Given this list of marker genes DDX55, DUSP15, PSMB7, JKAMP, ECHDC1, TAF1A, RPRD1A, PTPRK, EMB, SNX13, SDAD1, ZBTB44, WDR5, AP1G2, CEP95, GGA2, CAPN7, ABI2, AEN, C1orf159, NBEAL1, DUSP12, EEF1G, GART, STAG3, RAB6A, RTN4, ZNF679, ARFIP1, RNF103, NIPBL, IPCEF1, MTURN, DIP2A, KDM1B (lysine demethylase 1B), ACADM, DAGLB, RECK, SWT1 (SWT1 RNA endoribonuclease homolog), PSMG2, PDE2A, SLC16A8, SESN1, ATP6V1D, CBX7, METAP1D, VPS13A, SORL1, YBX1, GRK6, LRRC75B, PTBP3, CDKL2, TAGAP, GARIN3, HNRNPF, LRRC40, RNF145, P2RX4, SETD7, RGS20, AMY2A, PTS, MAN2A1, STOML1, CARNMT1, TTC28, HMGB1, UBASH3B, GLCCI1, PTPN12, SMPD5, KLRK1, NTAQ1, RAB2A, ZDHHC23, THEMIS, SLC35D2 (solute carrier family 35 member D2), PANK1, ABCC5, EFEMP1, SLC7A3, OAZ2, PTCH1, UBE2Q2, TTYH3, MADD, BIVM, ARHGEF3, RPS6KA5, COQ3, MAP1LC3B, FGF2, C19orf38, CSNK2A1, SMC4, MALT1, ASB1, XPC, ZBTB20, ATP8B2, ARHGAP18, ARFRP1, PON2, GUCD1, SPRY1, RXRA, APPL2, IP6K1, VSIR, C12orf75, TMEM267, STK26, PXYLP1, GLE1, RBM27, YWHAZ (NCBI Gene Id 83242), LDLRAP1 (NCBI Gene Id 81862), RB1CC1, CYP2S1, PURG, TUBA1A, CRYBG3, ANKMY2, GTF2I, GRAMD4, PFAS, DHRS11, SRGAP2, ARL4A (ADP ribosylation factor like GTPase 4A), UAP1, ACSBG1, RUNX2, ACOT9, NAE1, RNF141, NEAT1, SPOP, DSN1, ZNF318, SLC35E3, EVI2B, TIMM21, ME3 (malic enzyme 3), RORA, HNRNPA0 (heterogeneous nuclear ribonucleoprotein A0), RDH10, FNDC1, DTX4, KLHL6, FASTKD1, RAMP1, ANKH, MICALL1, DHFR, MYH9, NCAPD3, UBE2D2, PCMTD1, PLA2G4F, CDC25B, HSD11B2, METTL2B, UBQLN1, ZNF251, CXXC5, UBE2H, B3GALNT2, SORBS1, FCGR2A, CDC42SE2, OTUD1, ATRN, MORN2, ARHGAP31, MCOLN3, RHEBL1, SRSF5 (NCBI Gene Id 6430), UTRN, KMT2E, CISD3, TRAK1 (NCBI Gene Id 22906, trafficking kinesin protein 1), EGFL6, SLC25A26, ATXN3, CDC14B, DGKB, FAM117B, TPCN1, CEP78, FAM177A1, PIEZO1, ISCA2, TMX4, RNF144A, SF1, JADE2 (jade family PHD finger 2), ADH5, TMBIM1, RNF39, here is a description of the gene set: from publication Ventre E, Brinza L, Schicklin S, Mafille J, Coupet CA, Marçais A, Djebali S, Jubin V, Walzer T, Marvel J (PMID 22942430) Effects of IL-4 on CD8 T cells functions are largely unknown. IL-4 induces survival and proliferation of CD8 T cells, but several studies suggest that IL-4 could also affect several functions of CD8 T cells such as cytotoxicity. Our team has shown that IL-4 repress the expression of Ccl5 in vitro. To define more precisely the impact of IL-4 on CD8 T cells, we performed a whole genome expression microarray analysis of naive and memory CD8 T cells cultured in presence or absence of IL-4. This approach allowed us to define the IL4-gene-expression signature on CD8 T cells. Human Gene Set: GSE32423_IL7_VS_IL7_IL4_MEMORY_CD8_TCELL_UP Genes up-regulated in comparison of memory CD8 T cells treated with IL7 versus those treated with IL4 and IL7. species: Homo sapiens